The following is a description of a gene set: species: Mus musculus Mouse Gene Set: chrXC2, and this is the list of marker genes: Gm8908, Gm14783, Gm14785, Gm14784, Mageb1 (MAGE family member B1), Gm16465, Mageb5b, Mageb17-ps, 1700084M14Rik, Gm7113, Gm14786, Mageb6b2, Gm5071, Mageb5, Gm8916, Gm4911, Gm4912, Mageb6b1, Mageb2